The following is a description of a gene set: species: Homo sapiens The series of molecular signals which triggers the apoptotic death of a cell. The pathway starts with reception of a signal, and ends when the execution phase of apoptosis is triggered. Human Gene Set: GOBP_APOPTOTIC_SIGNALING_PATHWAY, and this is the list of marker genes: MOAP1, HMOX1, SGK3, MAP2K4, IL1B, FADD, FAM162A, JAK2, TP73, PPARD, CX3CR1, IKBKE, PPP2R1A, LCK, PRDX2, CTSH (NCBI Gene Id 1512), BECN1 (NCBI Gene Id 8678), MIR186, HYOU1, TRAF2 (NCBI Gene Id 7186), HNRNPK, KITLG, HIPK1, TRIAP1, MIR17, FZD1, HIF1A, MAPK9, ELL3 (NCBI Gene Id 80237), MIR132, TNFAIP3, NOG, ERO1A, BRCA2, USP15 (NCBI Gene Id 9958), IVNS1ABP, DAP, TNFRSF10C, MAGED1, S100A9, HSPE1, SFRP2, PARK7, IL10, SELENOS, PHLDA3, FCGR2B, CYP1B1, FAS, RNF183, NUPR1, SELENOK, BCL2L14, PLSCR3, CD24, SCN2A, LGALS12, SYVN1, SNAI1, SCRT2, CHCHD10, ERP29, IL7, LRRK2, FGF10, MKNK2, GSK3B, MIR133A1, LMNA, CD5, NCK1, SIAH1, ERN2, CDIP1, XPA, IFI27L1, POU4F1, TXNDC12, FZD9, SOD1, PDE3A, MAPK8IP2, STYXL1, DAPK3, PRODH, G0S2, LAPTM5, ARL6IP5, NANOS3, PPP2R1B, PARL, NGFR (nerve growth factor receptor), STK3, BAG3, TMEM102, GSTP1, TAF9, TMEM238L, TRADD, PDCD10, TMEM14A, HSPA1B, NCK2, SHISA5, BBLN, NR4A2, TP63, BAK1 (BCL2 antagonist/killer 1), HIP1, SEPTIN4, MIR221 (microRNA 221), IKBKG, MAPK8IP1, ATF4, GNAI2, TLR3, BIRC6, EDA2R, MYBBP1A, PDK2, EIF2AK3, SIVA1, TERT, GABARAP, BOK, RB1 (RB transcriptional corepressor 1), MMP2, BID, POU4F2, HERPUD1, POLB, DAPK1, MAP3K5, SNW1, STRADB, FGFR1, TNF, INHBA, SH3RF1, TP53, MMP9, GDNF, YAP1, WNT5A, RAF1, DAB2IP (NCBI Gene Id 84635), GPER1, TNFRSF12A, BIK, SERPINE1, NOX1, PRKN, WNT16, BCL2A1, FIS1, EYA1, PPARG, EPHA2, ITGA6, EP300, MYC, THBS1, NFKBIZ (NCBI Gene Id 64332), RELA, CRIP1, AGT, FLCN, BCL2L12, CUL3, ATF3, CUL4A, DDIAS, QRICH1, ATP2A3, BCL3, CD3E, CXCL12, NFATC4, FASTK, PAK5, RPL26, NKX3-1, HIP1R, BCL2L11, HYAL2, HSPA1A, MIR29B1, BCL2, SLC25A4, MUL1, NHERF1, SFPQ, TFPT, MSH6 (NCBI Gene Id 2956), PELI3, MNT, TPT1, BDKRB2, TMBIM1, TRIM32, RTKN2, SST, DAXX, CASP8, COL2A1, SORT1 (NCBI Gene Id 6272), PRKDC, TREM2, MIR26B, RIPK1, IL33, DEPTOR, UNC5B, FGF2, UBB, TGFBR1, ICAM1, DIABLO, GATA4, PIDD1, CTH, C8orf44-SGK3, CSNK2A1, UMOD, PDCD6, IGF1 (NCBI Gene Id 3479), PTH, PF4, KRT18, BCL2L2, PAK2, MIR195, NRP1, NGF, ADORA1, ING5, E2F2, KLF4, ATAD5, DEDD2, HMGB2, TNFRSF10A, CLU, UBE4B, TNFRSF1A, BCL10, SMAD3 (SMAD family member 3), SPI1, CD28 (NCBI Gene Id 940), APP, ATP5IF1, PPP1R13B, MIR146A, TRAP1 (TNF receptor associated protein 1), TNFRSF1B, JMY, ERBB3, FBXO7, PYCARD, RPS6KB1, FXN, DNAJC10, OPA1, RTL10, CTNNB1, RHOT2 (ras homolog family member T2), PSMD10, CLEC7A, PPIA, SLFN12, PTPN2, SYK, SOD2, CUL2, ATF2, BRCA1, CTNNA1, SMAD4, ACKR3, EEF1E1, RIPK3, CDKN1A, DDX47, TMEM109, FBH1, IFI27, MIR16-1, ARMC10, PSEN1, CTTN, URI1, SSTR3 (NCBI Gene Id 6753), BBC3, SLC25A31, PRKCA, ZNF385B, MIR21, FEM1B, SNAI2, BDNF, FBXW7, MADD, CD44, TNFSF12, MAGEA3, PRKCD, ERCC2, DAP3, ADORA2A, TPD52L1, MIR15A, HSPB1, INS, LCN2, GSK3A, DAPL1, ACVR1C, FGG, SP100, PEA15, TRAF1, SLC25A5, CASP8AP2, TM2D1, CD40LG, PTPN1, SRC, PLAUR, ITPR1, HRK, WNT4, PRKRA, PRELID1, GRINA, IFI27L2, ST20, AATF, TNFRSF10B, ACSL5, P2RX7, CARD9, RACK1, CSF2, NDUFA13, FGB, GHITM, CUL5, MAPK7, LGALS3, SIAH2, SFN, RNF186, MSH2, PINK1, BMP4, USP47, CAV1, AEN, TRIM39, CEBPB, MIR210, CIB1, MIR199A1, PSME3, ATM, ZNF205, USP28, CREB3L1, CD38, CASP4, MIF, CCAR2, ACVR1, FOXO3, CDKN2A, MELK, PAWR, FHIT, PPP1R15A, HIC1, EYA4, BCL2L10, IL1A, MIR19A, QARS1, TCF7L2, ITPRIP, ING2, TLR6, CASP3, ATP2A1, NOS3, HDAC1, MAZ, RET, BNIP3L, PTGIS, TRAF7, SPN, PYCR1, AGTR2, SLC35F6, CASP6, HTRA2, SFRP1, RFFL, MLH1, CREB3, STK24, METTL21C, FAF1, SGPP1, DAPK2, SLC25A6, BMI1, PIK3R1, KCNQ3, IL19, CX3CL1, EPO (erythropoietin), BNIP3, NODAL, EYA2, DDIT3, S100A8, VDAC2, GPX1 (glutathione peroxidase 1), BLOC1S2, PTPMT1, TMBIM6, SRPX, DDX3X, TMEM161A, TMC8, CYCS, PML, STK11, DPF2, TOPORS (NCBI Gene Id 641432), CD70, PTTG1IP (NCBI Gene Id 756), P2RX4, RNF41, SIRT1, BAD, SCG2, SKIL, GGCT, CDKN2D, TIFAB (TIFA inhibitor), WWOX, ATP7A, EI24, CASP9, LTBR, XBP1, IER3, YBX3, IFNB1, SGPL1, PDIA3, RRM2B, ITGAV, CD74, RRN3, CTSC, TICAM1, TNFSF15, PTPRC, PCGF2, NF1, STK4, GSDME, MIR449A, HINT1, MIR92A1, GSKIP, PDX1, WNT1, CFLAR, TP53BP2, UACA, ACVR1B, PERP, FGA, FAIM2 (Fas apoptotic inhibitory molecule 2), IFI16, SGMS1, MSX1, PHIP, UBQLN1, CD27, ZMYND11, IL2, AR, RPS3, NACC2, FASLG, ITM2C, NFE2L2, HTT, MUC1, P4HB, ACAA2 (acetyl-CoA acyltransferase 2), TMEM117, TNFRSF25, KRT8, CRH, ASAH2, CUL1, HELLS, IFNG, ZNF622, RNF34, STX4, IL12A (NCBI Gene Id 3592), PDK1, DIDO1, MAL, GFRAL, MPV17L, CSNK2A2, RAD9A, TGFB1, HGF, ARHGEF2, MLLT11, DDX5, PDPK1, ZSWIM2, AIFM1, MAP2K5, SHH (sonic hedgehog signaling molecule), ZDHHC3, SERINC3, STK25 (NCBI Gene Id 10494), MDM2, RBCK1, BEX3, EYA3, ANXA6, NONO, BMP5, TNFSF10, WFS1, DNAJA1, PARP2, GATA1, CASP2, NBN, MIR142, RPS27L, NOL3, PMAIP1 (phorbol-12-myristate-13-acetate-induced protein 1), NRG1, TAF6, CHEK2, ABL1, RRP8, PTGS2, BCLAF1, NLRP1, RB1CC1, TAF9B, GCLC, LTB, MAP2K1, ENO1, KDM1A, BAX, DYRK2, DDIT4, IL20RA, TLR4, IFI6, FNIP2, BCAP31, FIGNL1, INCA1, NME5, HIGD1A, INHBB, AKT1, FYN (FYN proto-oncogene, Src family tyrosine kinase), TP53BP1, MIR27B, RHOT1, MCL1, DELE1 (DAP3 binding cell death enhancer 1), PARP1, DEDD, GCLM, BMPR1B, BAG5, BAG6, CARD8, IL6R (interleukin 6 receptor), MIR222, PIAS4 (NCBI Gene Id 51675), TNFSF11, FGFR3, NOC2L, CHAC1, ERN1, PIK3CB, PPP2R5C, BMF, CIDEB, E2F1, PPIF, RPS7, TIMM50, EIF5A, PPEF2, FAIM, MAEL, MTCH2, ADCY10, BTK, HRAS, DBH, HIPK2, PPP1CA, ZNF385A, COA8, CYLD, MARCHF7, BCL2L1, CRADD, HSF1, TGFB2, BRSK2, TRIB3, SP1 (NCBI Gene Id 6667), APAF1, VNN1, TNFSF14, PLAGL2, ERCC6, LTA